The following is a description of a gene set: Human Gene Set: TRAVAGLINI_LUNG_MACROPHAGE_CELL studied in species Homo sapiens from publication Travaglini KJ, Nabhan AN, Penland L, Sinha R, Gillich A, Sit RV, Chang S, Conley SD, Mori Y, Seita J, Berry GJ, Shrager JB, Metzger RJ, Kuo CS, Neff N, Weissman IL, Quake SR, Krasnow MA (PMID 33208946), and this is the list of marker genes: NOP10 (NOP10 ribonucleoprotein), SIRPA, OLR1, FTL, CD81, GPX3, FN1, P2RX4, IL1A, ITGB8, AQP9, TGM2, SNX10, CTSB, TCF7L2, HLA-DRB6, CXCL3, MARCO, HNMT, ANXA2, YBX1, CST3, PLEKHB2, GPNMB, ISG15, STAC, MPHOSPH6, CCRL2, TUBB2A, GRN, DENND5A, HLA-DRB5 (NCBI Gene Id 731247), ACVRL1, TREM1, GSN, QSOX1, ANPEP, KYNU, ETHE1, CXCL8, CYBB, MCEMP1, CTSH, FCGR2A, SDC4, PSAP (prosaposin), IL1B, TYROBP, SLC7A7, YWHAH, RTN4, RAB10, CD163, CCL20 (C-C motif chemokine ligand 20), PLAUR, GLIPR2, CD9, ASAH1, PNPLA6, SOD2, FTH1, LPL, PLXDC2, TYMP, GSTO1, CXCL2, MS4A7, C15orf48, GLDN, PLSCR1, PDLIM1, MYD88, HBEGF, OSCAR, COMT, HCK, APOE, CSTA (NCBI Gene Id 378889), PGD, MT1M, ACTN1, ACSL1, TGFBI, IGSF6, SPATS2L, PLEC, FMNL2, MSR1, CAPG, FABP5, C1QA, FLVCR2, TNFAIP2 (TNF alpha induced protein 2), CTSD, HCAR2, BCL2A1, LHFPL2, RBP4, ABL2, C3AR1, KLF4, FBP1, SLC15A3, RAC1, GPX1 (glutathione peroxidase 1), RNF13, IL1RN, BID, SDCBP, HSPB1, ATP6AP1, S100A10, PILRA, NPC2, LYZ, VIM, ACER3, HLA-DRB1, GPX4, SMCO4, OTUD1, CD74, TSPO, SERPING1, LAP3 (NCBI Gene Id 5186), GRINA, DAB2, TREM2, VAT1, MGST3, MOB3B, CTSL, RHOB, MMP19, RGCC, INHBA, APLP2, IL6, C1orf162, SERPINA1, PPT1 (palmitoyl-protein thioesterase 1), MRC1, IGFBP2, RAB31, HLA-DQA1, C1QC, APOC1, SLC11A1, VSIG4 (V-set and immunoglobulin domain containing 4), IFI6, NUPR1, MS4A4A, AP2S1, HEXB, GLUL, CTSC, FAM89A, SLC43A2, CXCL1, FPR1, GPD1, CLIC4, VDAC1, MT1E, LTA4H, FCER1G, SLCO2B1, CXCL16, C1QB (NCBI Gene Id 713), ALOX5AP, CNDP2, ENG, ACP5, ATP6V1F, ANXA5, TUBA1C, ALDH2, COX17, RETN, HLA-DQB1, CSTB, CTSS (cathepsin S), S100A11, NCF2, DEFB1, CORO1C, LRP1, SIGLEC1 (NCBI Gene Id 6614), ATP6V1B2, FABP4, PPARG, HSBP1, LGALS3, GK, LGALS1, RASGEF1B, MGST1, AVPI1, SCARB2, CCDC88A, FCGRT